Given this list of marker genes ZNF667, MMP17 (matrix metallopeptidase 17), ASCC1, SLC39A11, GRHL2, PTTG1IP, ALG2, SLC66A3, OST4, BBS2, PLPP2, SYNE3, GPR137B, CORO6, CERS5, CFAP107, TMEM71 (NCBI Gene Id 137835), LRRC57, HACD4, RREB1, UBALD2, GMCL1, RAB3GAP2, FAM111A, RIN2, RAD9B, KIF24, SNX30, GSDME, NAT14, OR51B2, HIBCH, DCAF15, TPD52, S1PR1, TUSC2, PPP4R3B, NDUFS6, PATZ1, CNDP2, PDE3B, KNOP1, PALB2, ACSF2, IL11RA, CASP3, MRPL41, C1orf185, VAT1, DEPTOR, SMIM15, RAB5C, CD300LD, SPACA3, BCL2L1, CORO7, MED12, STXBP5, DAP, PFN3, BRF1, TRAPPC1, CACNA1F, TLR7, HPS3, NOSTRIN, CST3, EPB41, SGSH, SLK, CLIC3, INPP5K, C19orf47, CRTAM, CCR5, FAM234A, NR2F6, LBP, GAN, TFAP2A, CLPS, PCNT, MORN3, PYCARD, NBR1, SHARPIN, FOXRED2, LRRTM4, HPRT1, MAN2A2, CSNK1E, DUOX1, PRKX, MFSD12, TMEM86A, ITGB5, CLN6, TMEM241, HGF, SCAMP2, NUDT16, TFAP4, CCDC150, DOK2, ALOX5AP, NDUFB2, LYL1, ART5, ETV5, AGBL4, ADI1, TRIM8, MR1, SNX22, NFASC, PROSER2, PTK2B, GIPC1 (NCBI Gene Id 10755), INPPL1, DMAC2, FIBP, SCARB1, NHERF2, DNAJB11, TPGS2, PYCR2, RWDD2A, ARL15, ARFGEF2, TMEM87B, EMC1, DNAH17, TBXAS1, PLEKHO1, NFAM1, SELENOS, CHEK2, ANKRD37, COMMD7, CLEC4A (NCBI Gene Id 50856), CFAP410, NRROS, CEP128, LPIN2, CAMK1, STEAP3, LDB1, GLA, TECR, VPS26C, SLC8B1, ACOX3, DNAJC9, MMP8 (NCBI Gene Id 4317), FCGR1A, PPM1H, ENSA, FURIN, MRPL19, CACUL1, NDST2, BASP1, COMMD3, LYZL4, ADIPOR2, FAM89B, MSRB2, SLC7A4, CBX6, CNNM3, PLBD2, TTYH3, MDH1, MCFD2, TTC12, PINK1, EBPL (NCBI Gene Id 84650), MEF2A, PTMS, IRF2BPL, SIPA1, PWWP2B, USP6NL, SLC22A9, SNX8, KIF20B, CTDSP2, TXNIP, MELTF, MLEC, CELF2, CNP (2',3'-cyclic nucleotide 3' phosphodiesterase), CHRNA2, OXR1, AKT1S1, PIERCE2, MXI1, TNFRSF21 (NCBI Gene Id 51323), SEL1L3, here is a description of the gene set: IRAK-4 is an essential component of the signal transduction complex downstream of the IL-1- and Toll-like receptors. Though regarded as the first kinase in the signaling cascade, the role of IRAK-4 kinase activity versus its scaffold function is still controversial. In order to investigate the role of IRAK-4 kinase function in vivo, ‘knock-in’ mice were generated by replacing the wild type IRAK-4 gene with a mutant gene encoding kinase deficient IRAK-4 protein (IRAK-4 KD). Analysis of bone marrow macrophages obtained from WT and IRAK-4 KD mice with a number of experimental techniques demonstrated that the IRAK-4 KD cells greatly lack responsiveness to stimulation with the Toll-like receptor 4 (TLR4) agonist LPS. One of the techniques used, microarray analysis, identified IRAK-4 kinase-dependent LPS response genes and revealed that the induction of LPS-responsive mRNAs was largely ablated in IRAK-4 KD cells. In summary, our results suggest that IRAK-4 kinase activity plays a critical role in TLR4-mediated induction of inflammatory responses. Genes up-regulated in comparison of untreated macrophages from IRAK4 deficient mice at 4 h versus those treated with LPS (TLR4 agonist) at 4 h. studied in species Homo sapiens Human Gene Set: GSE9037_CTRL_VS_LPS_4H_STIM_IRAK4_KO_BMDM_UP from publication Koziczak-Holbro M, Glück A, Tschopp C, Mathison JC, Gram H (PMID 18266302)